Given this list of marker genes Vwf, Ear1, Cldn3, Ehf, Gsta3, Kdf1, Ceacam1, Ces1d, Mal, Mpzl2, Pglyrp1, Hid1, Sftpc, Cxcl15, Scgb1a1, Tacstd2, Esrp1, Fmo2, Sftpa1, here is a description of the gene set: Gene sets differentially expressed in the metastases of non-small cell lung adenocarcinoma tumors from Kras<LA1/+>; p53<R172HdeltaG/+> mice relative to paired primary lung tumors. A p53 missense mutation, R175H, found in Li-Fraumeni syndrome patients and in a subset of NSCLC patients, is a structural mutation that exhibits loss of function owing to inactivation of p53 transcriptional activity. Mutation of the corresponding arginine (R172H) in murine p53 has been previously introduced into the mouse as a knock-in allele. To evaluate the importance of p53<R172H> as a contributing event in lung tumorigenesis, p53<R172HdeltaG> mice were previously mated with Kras<LA1> mice, which develop lung adenocarcinomas owing to somatic activation of a latent Kras<G12D> allele, but rarely metastasize. from publication Gibbons DL, Lin W, Creighton CJ, Zheng S, Berel D, Yang Y, Raso MG, Liu DD, Wistuba II, Lozano G, Kurie JM (PMID 19404390) Mouse Gene Set: GIBBONS_GENETIC_MOUSE_MODEL_LUNG_ADENOCARCINOMA_DOWN_IN_METASTASIS studied in species Mus musculus